The following is a description of a gene set: from publication Meissner A, Mikkelsen TS, Gu H, Wernig M, Hanna J, Sivachenko A, Zhang X, Bernstein BE, Nusbaum C, Jaffe DB, Gnirke A, Jaenisch R, Lander ES (PMID 18600261) Human Gene Set: MEISSNER_ES_ICP_WITH_H3K4ME3 Genes with intermediate-CpG-density promoters (ICP) bearing histone H3 trimethylation mark at K4 (H3K4me3) in ES cells (embryonic stem). studied in species Mus musculus DNA methylation is essential for normal development and has been implicated in many pathologies including cancer. Our knowledge about the genome-wide distribution of DNA methylation, how it changes during cellular differentiation and how it relates to histone methylation and other chromatin modifications in mammals remains limited. Here we report the generation and analysis of genome-scale DNA methylation profiles at nucleotide resolution in mammalian cells. Using high-throughput reduced representation bisulphite sequencing and single-molecule-based sequencing, we generated DNA methylation maps covering most CpG islands, and a representative sampling of conserved non-coding elements, transposons and other genomic features, for mouse embryonic stem cells, embryonic-stem-cell-derived and primary neural cells, and eight other primary tissues. Several key findings emerge from the data. First, DNA methylation patterns are better correlated with histone methylation patterns than with the underlying genome sequence context. Second, methylation of CpGs are dynamic epigenetic marks that undergo extensive changes during cellular differentiation, particularly in regulatory regions outside of core promoters. Third, analysis of embryonic-stem-cell-derived and primary cells reveals that 'weak' CpG islands associated with a specific set of developmentally regulated genes undergo aberrant hypermethylation during extended proliferation in vitro, in a pattern reminiscent of that reported in some primary tumours. More generally, the results establish reduced representation bisulphite sequencing as a powerful technology for epigenetic profiling of cell populations relevant to developmental biology, cancer and regenerative medicine., and this is the list of marker genes: STOML1, PPP2R3C, TRIQK, CCDC160, WDR83OS, NCKAP5, LSG1, PRPF31, RTTN, RNF208, S1PR4, SHANK2, MPI, TAL2, C5orf34, DRC3, EPPK1, KCNIP2, TBC1D22B, PAK6, RBM4, NOSIP, CAPN1, TLR2, RPL19, FAM3A, PALM3, RAB13, ATP6V1G2, COL6A2, ZIK1, GDAP1L1